The following is a description of a gene set: studied in species Homo sapiens The phospholipase C (PLC) family of enzymes is both diverse and complex. The isoforms beta, gamma and delta (each have subtypes) make up the members of this family. PLC hydrolyzes phosphatidylinositol bisphosphate (PIP2) into two second messengers, inositol 1,4,5-trisphosphate (IP3) and diacylglycerol (DAG). IP3 mobilizes intracellular calcium stores while DAG activates protein kinase C isoforms which are involved in regulatory functions. part of: G-protein mediated events Reactome Pathway: PLC beta mediated events, and this is the list of marker genes: ADCY6, KPNA2, ADCY3, PRKACA, AHCYL1, ADCY9, GNA15, CAMK2A, PLCB3, ADCY1, ADCY5, NBEA, CAMKK2, ITPR1, PDE1A, ITPR3, PRKAR1B, ADCY7, GNA14, PRKAR1A, GRK2, PRKCG, PLCB4, ADCY8, PRKACG, CAMK4, CAMK2G, PDE1C, PRKAR2B, ITPR2, PRKX, ADCY4, PRKAR2A, MAPK1, CAMK2D, CAMK2B, PLA2G4A, PRKCA, PLCB2, GNA11, CAMKK1, PDE1B, ADCY2, PRKACB, GNAQ, PRKCD (protein kinase C delta), CREB1, CALM1, PLCB1